The following is a description of a gene set: Human Gene Set: GSE17974_CTRL_VS_ACT_IL4_AND_ANTI_IL12_12H_CD4_TCELL_DN The aim of this dataset was to study in detail the transcription kinetics initiated by cytokine IL-4 in early differentiation of Th2 cells. from publication Elo LL, Järvenpää H, Tuomela S, Raghav S, Ahlfors H, Laurila K, Gupta B, Lund RJ, Tahvanainen J, Hawkins RD, Oresic M, Lähdesmäki H, Rasool O, Rao KV, Aittokallio T, Lahesmaa R (PMID 20620947) Genes down-regulated in comparison of untreated CD4 T cells at 0 h versus the cells treated with IL4 and anti-IL12 at 12 h. species: Homo sapiens, and this is the list of marker genes: APIP, RBM28 (RNA binding motif protein 28), HCP5 (NCBI Gene Id 91955), GNG8, SMKR1, RRP9, CDK4, XCL1 (NCBI Gene Id 92337), MIPEP, MCAT, NAB2, OARD1, CLDN5 (NCBI Gene Id 7122), SMG9, HYOU1, DGAT2, SNRPD3, PAM, OSBPL3, WSB2, SSNA1, MTMR2, ARMC6, SCFD2, PSMB2, GAR1, NUP37, CLIC4, MRPL18, FAM98B, SLC38A5, RXYLT1, BLM, ERG28 (ergosterol biosynthesis 28 homolog), AIRIM, C17orf100, TMEM126B, NAA30, AIG1, NFE2L3, PSMA4, NUP42, TBL2, IFRD2, C1orf53, RUVBL2, SRM, PIGV, LYAR (Ly1 antibody reactive), FANCI, SPAG1, MLEC, RNGTT, SPTSSA, XPOT, CCL22, SLC25A11, PNO1, PDCD2L, UCK2, C12orf76 (chromosome 12 open reading frame 76), HAUS7, ID3, ZNF485, COA3, PUM3, PRPF38A, ANKS1A, GGCT, SEC11C, DPH2, BRIX1, MCUR1, PEMT, KEAP1, EMILIN2 (NCBI Gene Id 84034), TSEN2, MRPS28, SFT2D2, ZMYM6 (NCBI Gene Id 9204), SNHG12, RAP1A, POLD2, RNF34, IER3, MCM5, SLC37A3, GALE, RRS1, TRIB3, HOMER1, GLB1L2, POLR2H, NLE1, PUS10, POP7, GNPNAT1, MAD2L1, SMG5, RCC1, MTCH2, TRAF3, CTSL, GON7, TMEM165 (transmembrane protein 165), MED20, GTDC1, USH2A, TUBB, TARBP2, ATP1B3, FKBP4, TIAM1, NANP, SPRED2, SPINT2, SH2D2A, IPO7, PPP1R14B, AARS1, IL18R1, VBP1, CD200, TBC1D24, AAAS, FTSJ3, GLS, ELOVL1, ORMDL2, MARS2, SLC7A1, FNTB, PSMG1, USP45, TMCO6, ZNF232, TMEM121, GOT2, OR7E36P, MRPL17, ARHGAP11A, FADD, BBS7, DESI1, ENDOG, RCC1L, TP53BP1, DNPH1, MIR17HG, FAM162A, KLHL18, ELAVL1, BAZ1B, SLC19A1, MLKL, MRPS26, INTS13, GPN3, BYSL, TOMM5, ZNF322, HSPE1, NIF3L1, FEN1, PIGM, DNAJA3, NEMP1, SENP5, ZNF593, BDH1, RAD51D, C1orf216, GRK3, EIF4EBP1, EGR3, VDAC1, LIMA1, SFT2D1, GLB1, SPRY4, GPR183, ATOX1, SORD, JAML (NCBI Gene Id 261728), SLC39A14, ZC3H10, INTS2, MED7, RAB27A, PAICS, NPW, CDK2AP2, CSTF3, CDK2AP1, TCF19, EED, ZWINT, SNRNP25, TRMT10C